The following is a description of a gene set: electronically inferred by orthology from the curated human pathway Reactome Pathway: Oncogene Induced Senescence studied in species Mus musculus This event has been computationally inferred from an event that has been demonstrated in another species.<p>The inference is based on the homology mapping from PANTHER. Briefly, reactions for which all involved PhysicalEntities (in input, output and catalyst) have a mapped orthologue/paralogue (for complexes at least 75% of components must have a mapping) are inferred to the other species. part of: Cellular Senescence, and this is the list of marker genes: Ets2, Erf, Cdkn2b, Ubb, Rps27a, Mapk3, Cdk4, Trp53